Given this list of marker genes Ranbp2, Pcbp1, Dtx3l, Chmp4b, Ssb, Emc6, Sell, Rbck1, Eif3b, Shisa5, Ndufa12, Nt5c3, Snrpf, Egr1, Rfc3, Chordc1, Ube2s, Marchf5, Pgd, Gpr18, Phf11b, Slfn8, Uqcrb, Rnf19b, B4galt5, Eed, Arf1, Ssr1 (signal sequence receptor, alpha), Ccr5, Gadd45b, Capza2, Gzmb, Rnf213, Tmem128, Ciao2b, Arfrp1, Mindy3, Ifit3, Cst7, Gadd45g, Vav3, Hspe1, Atp5f1b, U2af1, Eif1, Tmem33, Oasl2, Ahr, Sub1, Tmed2, Slc7a6os (NCBI Gene Id 69701), Ccdc25, Bzw1, Relb, Herc6 (hect domain and RLD 6), Eif2ak2, Helz2, Abhd17b, Iars1, Tomm20, Clic4, Smarce1, Ufd1, Eif4e, Srsf6, Mitd1, Hspa9, St13, Ctss, Evi2a, Prkcq, Gzma, Gng12, Gbp4, Man2a1, Dusp22, Cct7, Pml, Lman2, Ctps1, Psmb10, Iigp1, Ube2d3, Cxcl10, Etf1 (NCBI Gene Id 52117), Tgfb1, Psmb6 (NCBI Gene Id 19175), Ifit1, Gbp9, Utp6, Ccrl2, Atad1, Sp100, Napsa, Cct3, Tmem184b, Irf8, Atp5mf, Baz1a, Psmg4, Il12rb1, Plac8, Adora2a, Farsa, Atp5pb, Cd164, Tor1aip1, Serpinb9, Igtp, Trafd1, Rnf114, Samd9l, Usp18, Trp53, Nkg7, Prpf38a (NCBI Gene Id 69712), Zup1, Psma3 (proteasome subunit alpha 3), Muc1, Rbx1, Ifi213, Rbm3, Serbp1, Etnk1, Agfg1, Selenos, Tbx21, Ifi214, Aldoa, Ube2a, Dgkh, Smim7, Nup210, Tubb4b, Arf6, Orai1, Cgas, Aurkaip1, Oas3, Hspa5, Pim1, Ifih1, Phf5a, Oasl1, H2-Q7, Hnrnpd, Vapa (NCBI Gene Id 30960), Gnl3, Ube2n, Ddx21 (DExD box helicase 21), Tmem243, Nifk, Dynll2, Adar, Mxd1, Xbp1, 9930111J21Rik2, Ubb, Ivns1abp, Snx2, Arl5a, Ifi209, Hsp90aa1, Ifi206, Daxx, Ube2i, Cers6, Tap1, Oas1a, Tbrg1, Odc1, Lgals3bp, Ubald2, Tmed5, Irf9, Agpat3, Cycs (cytochrome c, somatic), Osm, Ifi47, Ifi211, Gem, Calhm6, Gpr171, Ogfr, Ms4a6b (NCBI Gene Id 69774), Actg1, Aars1, Slfn1, Gfpt1, Nmi, Gtf2f1, Eif5a, Trim34a, Aida, Bst2, Pfdn2, Gbp7, Sec61g, Nsd3, Gbp2, Ccl4, Npm1 (nucleophosmin 1), Pole4, Mycbp2, Ifitm3, Nampt, Tbc1d1, Mat2a, Cpne3, Clec2d, Nlrc5, Cox7a2, Fyb1, Crlf2, Nasp, Myd88, Irf1, H2-T24, Scarb2, Ube2l3, Max, Top1, Rigi, Chchd1, Cct5, Srsf2, Dnajb6 (NCBI Gene Id 23950), Cyb5b, Phf6, Ly6e, Pole3 (NCBI Gene Id 72024), Ncr1, Ccl3, Tnfsf8, Trim25, Bcl3, Lsm6, Fkbp2, Cd86, Map2k1, Stk39, H13, Trim12c, Ddx39a, H2-T22, Nhp2, Mvb12a, Hspa8, Abcb1a, Arf4, Tex2, Sar1a, Lilrb4b, Tap2, Slfn9 (NCBI Gene Id 237886), Il2rg, Pomp, Atp6v1g1, Nfkb2, Cd69, Psmb2, Fasl, Klrk1, Irgm1, C1qbp, Psmb5, Sytl3, Azin1, Xaf1, Zfp706, Naa20, Svbp, Mapk6, Mx1, Nars1, Fubp1, Sipa1l1, Ssr2, Dkc1, Psmd12, Ddx24, Snu13 (SNU13 homolog, small nuclear ribonucleoprotein (U4/U6.U5)), Ifit1bl1, Srsf7, Ubxn4, Arpp19, Atp5pf, Dennd4a, Lax1, Ptma, Stx11, Timm8a1, Cysltr2, Psat1, Trim30d, Icam1, Pdia3, Polr1h, Hnrnpdl, Ifit3b, Rheb, Caprin1, Psme1, Car5b, Stat3, Psma5, Psmb9, Gmppb, Ubr4, Runx3, Setbp1, Ncl (nucleolin), Srsf3, Serpina3g, Il3ra, Psmb8, Litaf, Snx3, Pa2g4, Parp14, Tcerg1, Fundc2, Ms4a4c, Il2ra, St6galnac4, Magoh, Spcs2, Hsp90b1, Calr, Mrpl15, B2m, Ddx60, Txnl4a, Morc3, Snrpd1, Hsp90ab1, H2-M3, Rel, Frmd4b (NCBI Gene Id 97338), Dnaja1, Vps54, Ifi27l2a, Tcp1, Gimap9, Ccnd2, Mbnl2, Ssr4, Ascc3, Socs1, Mctp2, Wdr43, Snrpa1, Slc25a5, Lyar, Hnrnpab, Tcof1, Stat1, Tapbp (NCBI Gene Id 28066), Psmd11, P2ry14, Xdh, Mgat1, Cyrib, Isg15, Ifi208, Bak1, Ly6a, Tor3a, Trim30a, Myc, Ahsa1, Pttg1 (pituitary tumor-transforming gene 1), Ssrp1, Metrnl, Larp1, Myl12a, Ttc39b, Hectd1, Rsad2, Ndufab1, Snrpa, Mrpl30, Smchd1, Pam16, Ufm1, Ppp1r11, Hsph1, Atp13a1, Plscr1, Ebna1bp2, Rap1a (NCBI Gene Id 99734), Plaat3, Nop58, Hsh2d, Tpm4, Dhx58, Furin, Txndc9, Isg20, Tgtp2, Hdlbp, Zcchc2, Ifi35, Tmbim6, Rabepk, Ogfrl1 (NCBI Gene Id 70155), Tcstv4, Crem (NCBI Gene Id 12916), Psma4, Ranbp1, Tuba1c, Hnrnpu, Casp4, Gng2, Magohb (NCBI Gene Id 66441), Tmem167, Strap, Ilrun, Hspa4, Nr4a3, Selenow, Psmc5, Jaml, Mrpl16, Prf1, Rnf157, Eef1e1, Hopx, Gpr65, Nip7 (NCBI Gene Id 76155), Asb13, Sh3bp2, Alyref, Sp110, Pcgf5, Ppa1, Cacybp, Plek, Mov10, Zbp1, Pdia6, Parp12, Ptpn1, Ywhae, Snrpb, Eloc, Atp2a2, Znfx1, Mmadhc, Sh3glb1, Dnajb11, Lgals9 (lectin, galactose binding, soluble 9), Ndufs4 (NADH:ubiquinone oxidoreductase core subunit S4), Stat2, H2-K1, G3bp1, Ezr, Parp9, Trim56, Zc3hav1 (zinc finger CCCH type, antiviral 1, NCBI Gene Id 78781), Rtp4, Ifi204, Cmpk2, H2-T23, Slfn5, Slamf7, Ifi44, Tnfrsf9, Rab5c, Ms4a4b, Ifng, Gimap5, Trim12a, Chchd2, Tspan13, Cnp, Zdhhc21, H2-D1, Slco3a1, Arpc5, Slfn2, Epsti1, Eif4a1, Mapkapk2, Samsn1, Xcl1, Usp25, Irf7, Picalm, Ifi203, Phf11c, Sh2d1b1, Socs3, Psmb4, Copb2, Laptm4a, Rabggtb, Ran, Zcrb1, Gimap4, Parp10, Uba7, Ghitm, Slc25a22, Fbl, Dnttip1, Ehd4, Timm10, Stip1, Pfn1, Tuba4a, Tspo, Tmsb10, Hspd1, Sumo2, Casp8, Samhd1, Ifit2, Rcc2, Txn1, Cd47, Psme2, Ppig, Cd53, Ppm1h, Chsy1 (chondroitin sulfate synthase 1), Serpina3f, Lamp2, Psma2, Mrto4, Snrpd3, Suz12, Cish, Riok1, Mndal, Cops3, Cd274, Phf11a, Il2rb, Eif2s2, Manf, Mrpl52, Cct8, Treml2, here is a description of the gene set: Cytokines mediate cell-cell communication in the immune system and represent important therapeutic targets. A myriad of studies have highlighted their central role in immune function, yet we lack a global view of the cellular responses of each immune cell type to each cytokine. To address this gap, the authors created the Immune Dictionary, a compendium of single-cell transcriptomic profiles of more than 17 immune cell types in response to each of 86 cytokines (>1,400 cytokine-cell type combinations) in mouse lymph nodes in vivo. A cytokine-centric view of the dictionary revealed that most cytokines induce highly cell-type-specific responses. For example, the inflammatory cytokine interleukin-1β induces distinct gene programmes in almost every cell type. A cell-type-centric view of the dictionary identified more than 66 cytokine-driven cellular polarization states across immune cell types, including previously uncharacterized states such as an interleukin-18-induced polyfunctional natural killer cell state. Mouse Gene Set: CUI_NK_CELL_IFNA1_RESPONSE_UP from publication Cui A, Huang T, Li S, Ma A, Pérez JL, Sander C, Keskin DB, Wu CJ, Fraenkel E, Hacohen N (PMID 38057668) Genes positively differentially expressed in cell type: NK cell upon treatment with cytokine: IFN-α1 in mouse lymph nodes in vivo. species: Mus musculus